Given this list of marker genes DDX10, GATA1 (NCBI Gene Id 2623), XRCC6, ZNF254 (NCBI Gene Id 9534), CITED2, MYCN (MYCN proto-oncogene, bHLH transcription factor), TFAP4, WRN, ELOA, DDX5 (NCBI Gene Id 1655), OGA, DDX1, BLM, SOX9, ATRX, JUNB, PRP4K, HELZ, EIF4A2, FOS, STAT2, TRIM28, CHD4, ERCC3, DDX23, XRCC5, GTF2F2, FOSL1 (FOS like 1, AP-1 transcription factor subunit), DHX8, DHX9, KLF7, here is a description of the gene set: Human Gene Set: MODULE_229 species: Homo sapiens Genes in the cancer module 229.